Given this list of marker genes DCK, ADK, DGUOK, TK2, TK1, here is a description of the gene set: Human Gene Set: GOMF_DEOXYNUCLEOSIDE_KINASE_ACTIVITY studied in species Homo sapiens Catalysis of the reaction: ATP + 2'-deoxynucleoside = ADP + 2'-deoxynucleoside 5'-phosphate.